Given this list of marker genes CAV3, ANK2, BIN1, CSRP3, ATP2A2, SYPL2, here is a description of the gene set: A process that is carried out at the cellular level that results in the assembly, arrangement of constituent parts, or disassembly of the T-tubule. A T-tubule is an invagination of the plasma membrane of a muscle cell that extends inward from the cell surface around each myofibril. species: Homo sapiens Human Gene Set: GOBP_T_TUBULE_ORGANIZATION